Given this list of marker genes Cyp4a12b, Cyp4a12a, Fdx1, Cyp4f15, Cyp4a29, Coq6, Cyp11a1, Cyp11b2, Cyp4a14, Cyp4a32, Cyp4f18, Cyp27a1, Cyp4a31, Cyp4a30b, Cyp4f14 (NCBI Gene Id 80440), Cyp11b1, Cyp4a10, here is a description of the gene set: studied in species Mus musculus Mouse Gene Set: GOMF_OXIDOREDUCTASE_ACTIVITY_ACTING_ON_PAIRED_DONORS_WITH_INCORPORATION_OR_REDUCTION_OF_MOLECULAR_OXYGEN_REDUCED_IRON_SULFUR_PROTEIN_AS_ONE_DONOR_AND_INCORPORATION_OF_ONE_ATOM_OF_OXYGEN Catalysis of an oxidation-reduction (redox) reaction in which hydrogen or electrons are transferred from reduced iron-sulfur protein and one other donor, and one atom of oxygen is incorporated into one donor.